Given this list of marker genes STXBP1, KCTD12, ATP9B, PCSK7, GNA15, APOBEC1, GABRQ, RGL1, MAGOHB, HDAC1, KRCC1, ELF1, SFXN2, KATNA1, ASPA, LLGL1, CSF1, TENT2, TFG, VPS54, ACTRT2, IGFBP5, MDFIC, SGCB, SCIN (scinderin), TXLNB, G3BP2, TSPO, FRAT1, EHD4, CCND2, BFAR, DERL3, IFI27L2, MEF2C, FOXRED1, SDHA, PLEKHF2, AEBP2, ST3GAL1, OSER1, SPINT2, TMEM209, FNDC3A, BATF2, DNAJA2, COX15, RFX5 (regulatory factor X5), AOPEP, RAMP3, GKN2, GPSM2, GUK1, DPF1, LRRK2, KLF3, LUC7L3, PRPF38A, CXCL9, TOB1, ATP8A1, IL12B, FGF5, DENND4C, ZFPM1, CNIH4, MET, SSPOP, TFIP11, GAST, RGS1, TRAF3IP2, SH3BP2, NAT1, LIPA, HMGN3, RGS18, TAF1B, TLE6, CXCL11, BST1, ARX, NDUFA9, INTS4, KBTBD4, TRIOBP, CPNE3, NEUROG3, HINFP, STXBP3, ATG4D, RBBP8 (NCBI Gene Id 5932), SLCO3A1, VPS50, GNAQ, DBNDD2, TAMALIN, ZFP36, CTRL, MPP1, FBXW11, LCP2, RNF214, CARD14, PEX26 (peroxisomal biogenesis factor 26), EMB, COX20, PUDP, SOWAHC, GRID2, PSMD7, SOX10, RASGRP1, RMDN3 (NCBI Gene Id 55177), SAV1, TLR8, GPR65, SMPDL3A, PELI1, KDM6A, TMEM243, PPP1R15B, DUSP2, MOCS2, FARP2, REL, BPHL, WDR86 (NCBI Gene Id 349136), MPP2, RABGAP1L, MVP, POLE4, SMC5, MTMR14, ASF1A, RNF34, NUB1, PHF13, AKT2, CD83 (NCBI Gene Id 9308), APAF1, IFT172, SP110, C9orf85, GK, GLIPR2, USB1, WDR43, ATG12, EFR3A, SLC28A2, TOMM70, HLA-E, NDRG1, FUT8, SLAMF7, PCBD1, USP47, CPEB3, MITD1, FEZ2, DNM1, FLNC, EXT1, HHEX, RAB9A, PGAP4 (NCBI Gene Id 84302), IRF7, COL6A3, ADAP2, SLC4A8, NKX6-1, CUTC, SLC25A25, ATP11B, EMC10, CPE, TCF4, CCDC9, RRAGC, ABCG2, BCL9, SMAD1, PSEN2, LOXL4, DCTN3, BNIP2, PLCL2, RABEPK, AMOTL2, STAG2, GPR37L1, SNAP23, TNIP2, PTH, RGS10, SEPTIN10, LRR1, TNFSF10, ADAM23, here is a description of the gene set: mouse primary BMDCs were stimulated with tlr ligands and gene expression changes were profiled on Affymetrix arrays Genes down-regulated in comparison of dendritic cells (DC) stimulated with Pam3Csk4 (TLR1/2 agonist) at 6 h versus DC cells stimulated with Gardiquimod (TLR7 agonist) at 6 h. Human Gene Set: GSE17721_PAM3CSK4_VS_GADIQUIMOD_6H_BMDC_DN studied in species Homo sapiens from publication Amit I, Garber M, Chevrier N, Leite AP, Donner Y, Eisenhaure T, Guttman M, Grenier JK, Li W, Zuk O, Schubert LA, Birditt B, Shay T, Goren A, Zhang X, Smith Z, Deering R, McDonald RC, Cabili M, Bernstein BE, Rinn JL, Meissner A, Root DE, Hacohen N, Regev A (PMID 19729616)